The following is a description of a gene set: from publication Vanasse GJ, Winn RK, Rodov S, Zieske AW, Li JT, Tupper JC, Tang J, Raines EW, Peters MA, Yeung KY, Harlan JM (PMID 15561778) The t(14;18)(q32;q21), resulting in deregulated expression of B-cell-leukemia/lymphoma-2 (Bcl-2), represents the genetic hallmark in human follicular lymphomas. Substantial evidence supports the hypothesis that the t(14;18) and Bcl-2 overexpression are necessary but not solely responsible for neoplastic transformation and require cooperating genetic derangements for neoplastic transformation to occur. To investigate genes that cooperate with Bcl-2 to influence cellular signaling pathways important for neoplastic transformation, we used oligonucleotide microarrays to determine differential gene expression patterns in CD19+ B cells isolated from Emu-Bcl-2 transgenic mice and wild-type littermate control mice. Fifty-seven genes were induced and genes were repressed by > or =2-fold in Emu-Bcl-2 transgenic mice (P < 0.05). The suppressor of cytokine signaling-3 (SOCS3) gene was found to be overexpressed 5-fold in B cells from Emu-Bcl-2 transgenic mice. Overexpression of Bcl-2 in both mouse embryo fibroblast-1 and hematopoietic cell lines resulted in induction of SOCS3 protein, suggesting a Bcl-2-associated mechanism underlying SOCS3 induction. Immunohistochemistry with SOCS3 antisera on tissue from a cohort of patients with de novo follicular lymphoma revealed marked overexpression of SOCS3 protein that, within the follicular center cell region, was limited to neoplastic follicular lymphoma cells and colocalized with Bcl-2 expression in 9 of 12 de novo follicular lymphoma cases examined. In contrast, SOCS3 protein expression was not detected in the follicular center cell region of benign hyperplastic tonsil tissue. These data suggest that Bcl-2 overexpression leads to the induction of activated signal transducer and activator of transcription 3 (STAT3) and to the induction of SOCS3, which may contribute to the pathogenesis of follicular lymphoma. Mouse Gene Set: VANASSE_BCL2_TARGETS_DN species: Mus musculus Genes down-regulated in primary B lymphocytes engineered to overexpress BCL2., and this is the list of marker genes: Myb, Ackr2, Trps1, Pglyrp1, Mfhas1, Tcstv4, Abcc1 (NCBI Gene Id 94110), Traf1, Cr2, Cmtm3, F13a1, Stmp1, Cyfip1, Terb1, Npn2, Anxa4, Bcl2, Cfp, Cd1d1, Ctsg, Lyz1, Marcks, Herc6, Tmem25, Plxnc1, Cmtr1, Carmil1, Nfkbid, Fn1, Dennd2d, Hcst, Cd9, Dph5, Lilrb4a, Ell3, Lta, Lig3, Map4k4, Mpo, Edaradd, Mphosph9, Tubg2, Mmut, Bid, Zfp991, Ifi207, Tcf7 (transcription factor 7, T cell specific), Ccnd2, 1600014C10Rik, Ackr3, Pla2g7 (phospholipase A2, group VII (platelet-activating factor acetylhydrolase, plasma)), Col5a1, Nedd4, Mcoln3, Ptpn22, Ccr1, Myl4, Pik3r4, Lilrb4b, Rtel1, Spmip4, Trmt10a, Kif20a, Rasgef1b